The following is a description of a gene set: Generalized excessive, abnormal hairiness. Generalized hypertrichosis studied in species Homo sapiens Human Gene Set: HP_GENERALIZED_HYPERTRICHOSIS, and this is the list of marker genes: NEU1, SRCAP, KCNH1, SETBP1, KCNN3, KMT2A, ATP6V1B2